The following is a description of a gene set: electronically inferred by orthology from the curated human pathway Reactome Pathway: Synthesis of PIPs at the early endosome membrane species: Mus musculus This event has been computationally inferred from an event that has been demonstrated in another species.<p>The inference is based on the homology mapping from PANTHER. Briefly, reactions for which all involved PhysicalEntities (in input, output and catalyst) have a mapped orthologue/paralogue (for complexes at least 75% of components must have a mapping) are inferred to the other species. part of: PI Metabolism, and this is the list of marker genes: Pik3c2a, Mtmr12, Pi4k2a, Mtmr4, Pik3c3 (phosphatidylinositol 3-kinase catalytic subunit type 3), Fig4, Inpp4b, Mtmr2